Given this list of marker genes UBE2V1P6, RBM45, RNU6ATAC14P (RNA, U6atac small nuclear 14, pseudogene), CDCA7, HOXD13, CWC22, FTH1P20, KRT8P40, PDE11A, RPSAP25, DHRS9, RPA3P1, PPIG (peptidylprolyl isomerase G), RAPGEF4-AS1, LINC01934, ERICH2-DT, HAGLR, DLX1, ABCB11, OLA1, AGPS, ENSG00000226681, MTX2, RNU6-629P, SESTD1, CYB5AP2, METTL8, RPS15P4, SDHDP5, DNAJC19P5, H3P6, RNA5SP113, HOXD11, PPP1R1C, NEUROD1, CCDC141, ENSG00000206961, PLEKHA3, RNU7-104P, HOXD3, UBE2E3, MIR3128, FUCA1P1, CHRNA1, RNA5SP112, RAPGEF4, CYBRD1, GORASP2, ENSG00000227098, IFT70B, GPR155-DT, HOXD10, HNRNPA1P39, HOXD12, LINC01305, UBR3, LINC01960, EVX2, ATF2, CFAP210, RNU6-5P, DLX2-DT, FKBP7, KLHL41, DYNC1I2 (NCBI Gene Id 1781), EXTL2P1, SAP18P2, HAGLROS, ITGA4 (NCBI Gene Id 3676), RNU6-1290P, SP5, HOXD4, IFT70A, FASTKD1, UBE2E3-DT, KRT18P29, RPL29P8, RPSAP24, MIR10B, ATP5MC3, HOXD8, DLX2, TTN, EIF2S2P4, NRAL, RPL27AP3, API5P2, MIR1246, RPS2P18, HAT1, CIR1, SPC25, ITGA6-AS1, LRP2, ITPRID2-DT, ENSG00000239041, MIR6512, SSB (small RNA binding exonuclease protection factor La), ITPRID2, RNU6-187P, PHOSPHO2, ENSG00000307295, H3P7, RNU6-1006P, HOXD-AS2, CHROMR, RPL21P38, DCAF17, TXNL4AP1, GPR155, BBS5, HOXD1, CYCTP, SCHLAP1, CHN1, PDK1, METAP1D, ALDH7A1P2, LRRC2P1, PDE11A-AS1, KLHL23, ITGA6, MIR7704, JPT1P1, ENSG00000286557, RNU6-182P, MIR4444-1, LINC01124, CBY1P1, ENSG00000238295, ENSG00000280636, NSA2P5, ENSG00000213963, ZNF385B, TTN-AS1, RPS15AP14, PRKRA, SCRN3, MIR1258, RNU6-763P, NUDCP2, MYO3B-AS1, GAD1, TLK1, MIR933, RPL5P7, MYO3B, METTL5, MAP3K20, SP3, STUB1P1, RNU6ATAC19P, PJVK, RPL21P31, PTCHD3P2, HOXD9, SP9, DAP3P2, HNRNPA3, OSBPL6, ERICH2, CERKL, WIPF1, MIR4437 (NCBI Gene Id 100616213), MAP3K20-AS1, RN7SL65P, LINC01116, PPIAP67, RNU5E-9P, LINC01117, PPIAP66, HMGB1P4, NFE2L2, G6PC2, RPS6P2, RAD52P1, RPS26P20, SLC25A12, LNPK, here is a description of the gene set: species: Homo sapiens Human Gene Set: chr2q31